Given this list of marker genes Mmrn1, Htr2a, Emilin1, Il6, Ctsg, Il6ra, Mfsd2b, Emilin2 (NCBI Gene Id 246707), F11r, Jak2, Pdpn, here is a description of the gene set: species: Mus musculus Mouse Gene Set: GOBP_POSITIVE_REGULATION_OF_PLATELET_AGGREGATION Any process that activates or increases the frequency, rate or extent of platelet aggregation. Platelet aggregation is the adhesion of one platelet to one or more other platelets via adhesion molecules.